The following is a description of a gene set: Any structural abnormality of the carotid arteries, including the common carotid artery and its' arterial branches. Human Gene Set: HP_ABNORMAL_CAROTID_ARTERY_MORPHOLOGY species: Homo sapiens Abnormal carotid artery morphology, and this is the list of marker genes: STX1A, UBE2T, SMAD2, FANCC, PRKG1, ELN, XRCC2, NDE1 (NCBI Gene Id 95348), LOX, TBL2, CLIP2, AEBP1, STAT1, SLC2A10, APOB, RAD51, THSD4, MAT2A, FANCF, FANCL, FANCA, SMAD4, MYLK, PALB2 (partner and localizer of BRCA2), COL5A1, NKX2-6, FKBP6, VPS37D (NCBI Gene Id 171020), SON, PCGF2, TMEM270, FANCG, ABCG8 (ATP binding cassette subfamily G member 8), MYH11, ZMPSTE24, RAD51C, NCF1, BRIP1, HOXA1, BRCA2, TGFB2, ATP7A, FANCB, FANCE, FANCD2 (NCBI Gene Id 2177), BUD23, ERCC4, TGFBR1, RFWD3, FANCI, SLX4 (NCBI Gene Id 84464), SMAD3, TGFBR2, PLXND1, ADA2, ANO1, EIF4H, LDLR, DNAJC30, LIMK1, ACTA2, HEY2, METTL27, COL3A1, BRCA1, DCDC2, ABCG5, IPO8, BAZ1B, ABCA1, LMNA, FOXE3, SDHD, GTF2I, MAD2L2, TMEM67, GTF2IRD2, TBX1, FBN1, TGFB3, FANCM, THSD1 (thrombospondin type 1 domain containing 1), LDLRAP1, GTF2IRD1, MFAP5, PCSK9, LMX1B, YY1AP1, RFC2, HTRA1, NF1